The following is a description of a gene set: Mouse Gene Set: GOBP_T_CELL_PROLIFERATION_INVOLVED_IN_IMMUNE_RESPONSE species: Mus musculus The expansion of a T cell population by cell division as part of an immune response., and this is the list of marker genes: Trp53, Tnfsf18, Slfn2, Rps6, Slc11a1